The following is a description of a gene set: studied in species Homo sapiens Human Gene Set: GOCC_APICAL_JUNCTION_COMPLEX A functional unit located near the cell apex at the points of contact between epithelial cells, which in vertebrates is composed of the tight junction, the zonula adherens, and desmosomes and in some invertebrates, such as Drosophila, is composed of the subapical complex (SAC), the zonula adherens and the septate junction. Functions in the regulation of cell polarity, tissue integrity and intercellular adhesion and permeability., and this is the list of marker genes: PLEKHA7, CLDN15, AMOTL2, AOC1, RAP2B, SHROOM4, PARD6A, EPCAM, MPP7, CLDN12, UBN1, RAB13, PDCD6IP, CRB2, NECTIN1, YAP1, DSG3, NECTIN3, RAP2C, TGFBR1, CLDN19, AMOTL1, FZD5, USP53, CLDN8, CLDN18, PARD3B, LIN7C, PRKCZ, JUP, EPPK1, MARVELD2, CAMSAP3, ACTB, PKN2, CLDN9, CLDN1, ESAM, BVES, RIGI, PRKCI, CYTH1, CTNNB1, NPHP1, SAPCD2, STRN, CLDN7, CRB3, ILDR2, KIFC3 (kinesin family member C3), CYTH3, SHROOM1, PALS1, F11R, MARVELD3, RHOA, CLDN11, FRMPD2, TJP2, MXRA8, ADCYAP1R1, APC, SH3BP1, NPHP4, CCND1, FRMD4B, LSR, SYNPO, RAPGEF2, AJM1, FBF1, CLDN10, EPB41L4B, RPGRIP1L (RPGRIP1 like), NHERF4 (NCBI Gene Id 79849), PARD3 (NCBI Gene Id 56288), CLDN4, CCDC85C, CYTH2, CDH5, JAM2, CLDN6, CLDN24, IGSF5, MAGI3, CGN, CLDN25, ANK3, SYMPK, CTNNA1, OCLN, VCL, CLDN22, CDK4, NHS, CLDN5, CLDN34, CLDN17, AMOT, CLDN14, LUZP1, MAPK15, OCEL1, VASP, PARD6B, CRB1, TRAF4 (NCBI Gene Id 9618), PLXDC1, SORBS1, FRMD4A, ARHGEF2, WNK4, MPDZ, CGNL1, YBX3, DLG3 (NCBI Gene Id 89363), PMP22, JAML, TBCD, WNK3, CCDC88C, C1QTNF5, CLDN16, NECTIN2, DLG1, CLDN20, CLMP, LIN7A, CLDN3, ILDR1 (immunoglobulin like domain containing receptor 1), SHROOM2, TJP1, MAGI2, VAPA, POF1B, CDH1, PATJ (NCBI Gene Id 10207), CXADR, WWTR1, ARHGAP17, MICALL2, CLDN2 (claudin 2), SHROOM3, TJAP1, ACTG1, FRMD6, PARD6G, ASH1L, MTDH, CLDN23, MAGI1, LIN7B, TJP3, ECT2, JAM3